The following is a description of a gene set: Human Gene Set: GOBP_POSITIVE_REGULATION_OF_DENDRITE_DEVELOPMENT Any process that activates or increases the frequency, rate or extent of dendrite development. species: Homo sapiens, and this is the list of marker genes: LRP8, VLDLR, PACSIN1, BMP5, COBL, TMEM106B, KHDC3L, ALK, EZH2, DAB2IP, PTN, ZDHHC15, BMP7, ABL1, BMPR1A, SMAD1